Given this list of marker genes Slc38a4, Slc1a4, Slc7a8, Slc3a2, Slc38a5, here is a description of the gene set: studied in species Mus musculus The directed movement of L-alanine across a membrane by means of some agent such as a transporter or a pore. Mouse Gene Set: GOBP_L_ALANINE_TRANSMEMBRANE_TRANSPORT